The following is a description of a gene set: Mouse Gene Set: GOCC_NEURON_PROJECTION_TERMINUS The specialized, terminal region of a neuron projection such as an axon or a dendrite. species: Mus musculus, and this is the list of marker genes: Prkcb, Grin1, Slc8a3 (solute carrier family 8 (sodium/calcium exchanger), member 3), Pdyn, Slc1a2, Gad1, Kcnab2, Ptprn2, Chrm3, Adora1, Npff, Hcn1, Casr, Slc4a10 (NCBI Gene Id 94229), Pgr, Actb, Glul, Calb1, Synj1, Unc13c, Scrg1, Aak1 (AP2 associated kinase 1), Cnga1, Gnrh1, Cckar, P2rx4, Epha4, Snca, Prkca, Unc13b, Dpysl2, Chrm2, Elk1, Grik5, Drd4, Uchl1, Kcnma1, Ppp2ca, Pacsin1, Rpl26, Ucn, Slc8a2, Calm2 (NCBI Gene Id 75700), Fkbp1a, Sri, Rapgef3, Kcnc3, Syt1, Kcnq5, Septin7, Slc8a1, P2rx3, Ghrh, Ror1, Septin6, Lrrk2, Scn9a, Tnn, Pcsk1, Ncs1, Kcna3, Mme, Tspoap1, Unc13a, Kcna1, Kcna2, Marcks, Scgn, Syp, Slc1a7, Grik2, Amph, Mical1, Bdnf, Git1, Calca, Anxa5, Cdh8, Mylk2, Rab5a, Grm4, Hspa8, Polg, Penk, Rimbp2, Vamp2, Grik4, Calm3, Drd2, Rapgef4, Itga2, Atcay, Cplx3, Ptbp1, Ntsr1, Kcnc1, Tbc1d24, Aqp1, Calb2, Ptpn9, Crhr2, Gria2, Dlg4, Nmu, Oprk1, Cplx1, Hnrnpr, P2rx2, Pclo, Ap3d1, Flrt1, Hap1, Sncb (synuclein, beta), Actg1, Mpp4, Prss12, Th, Kcnk2, Slc17a8, Tulp1, Git2, Cacna1b, Baiap2, Syt4, Gria4, Itsn1, Pebp1, P2rx7, Slc32a1, Chrm4, Apc, Nos1, Htr7, Ap1s1, Erc2, Grin2b, Syt11, Kcnc2, Htr1b, Cplx2, Arpc2, Glra1, Tprg1l, Bin1 (NCBI Gene Id 30948), Dgki, Fstl3, Maco1, Prrt2, Chrm1, Hcn3, Oxt, Cck, Atp1a3, Ophn1, Ntrk2, Ush2a, Pnmt, Slc6a3, Calm1, Slc1a1, Mob2, Synj2, Oprd1, Snap91, Elfn1, Drd1 (dopamine receptor D1), Srsf10, Rab3a, Grik3, Nts, Crhbp, Grin2a, Dbh, Fmr1, Septin4, Slc18a2, Ptprn, Rgs10, Cngb1, Prph, Syt7, Ilk, Flrt3, Hnrnpk (NCBI Gene Id 15387), Kcna6, Kcnc4, Gria3, Gabrb3, Ccl2, Blvrb, Esr1, Bsn, Slc18a1, Tanc1, Grip1, Dmd, Cyfip1, Clcn3, Btbd8, Got1, Cad, Slc18a3, Vti1a, Cyp19a1, Adcyap1 (NCBI Gene Id 11516), Prkcg, Adra2c, Sncg, Kcnip3, Tpbg (trophoblast glycoprotein), Opn1sw, Prnp, Prkn, Cplx4, Ptger4, Dixdc1, Pnoc, Slc9a6, Hcn4, Npy, Slc4a8, Atp6v0d1, Ucn3, Grm7, Grik1, L1cam, Septin5, Cdh1, Adra2a, Gper1